The following is a description of a gene set: Any process that modulates the frequency, rate or extent of TORC2 signaling. Human Gene Set: GOBP_REGULATION_OF_TORC2_SIGNALING studied in species Homo sapiens, and this is the list of marker genes: NCKAP1L, PIH1D1, TBK1, OTUD7B, SIK3, ARMH4, GSK3B, OTUD5, DEPTOR, RPS6KB1, EP300, AKT1 (NCBI Gene Id 207), USP9X